Given this list of marker genes Tac1, Tacr3, Tacr1, Tacr2, Tac2, here is a description of the gene set: Tachykinin receptors bind tachykinins Mouse Gene Set: REACTOME_TACHYKININ_RECEPTORS_BIND_TACHYKININS studied in species Mus musculus